The following is a description of a gene set: Human Gene Set: GSE45365_HEALTHY_VS_MCMV_INFECTION_CD11B_DC_IFNAR_KO_DN studied in species Homo sapiens Genes down-regulated in ITGAM+ dendritic cells with IFNAR1 knockout: control versus primary acute viral infection. Murine Cytomegalovirus (MCMV) infection leads to early activation of various immune cells, including B and T lymphocytes, before the actual initiation of antigen-specific adaptive immunity. This activation is partly driven by innate cytokines, including type I interferon (IFN), which are induced early after infection. The objective of this study was to address the role of type I IFN in shaping early/innate B and T cell responses to a primary acute viral infection. In order to decipher the specific impact of IFN-I on cell subsets, we performed a genome-wide expression analysis on WT splenic B and CD8 T lymphocytes isolated from C57BL/6 mixed bone marrow chimera mice. This study complements series GSE39555, which focused on early responses of NK cells and of the two subsets of conventional dendritic cells., and this is the list of marker genes: SEPTIN4, TRIOBP, TK1, NCAPG, STAU2, TMEM26, TEDDM1, LMBRD2, NAV3, ZNRF2P1, BPI, ADAMTS3, MSRB2, SDHC, CDC20, SEPHS2, BCL2L14, KIF15 (NCBI Gene Id 56992), SLC7A9, TOR1AIP2 (NCBI Gene Id 64163), PRKAG3, CLDN1, SNAP91, SKA3 (NCBI Gene Id 221150), LINC01139, TNKS2 (NCBI Gene Id 94771), RBM11, MIR503HG, FRK, G6PD, HPYR1, SSX1, MND1, MKI67, TRIQK, TKT, RASGRF1, UFD1, FIG4, KCNMA1, PCOLCE2, TMEM132D, KIF4A, CYP2B7P, CHMP4C, CDC27, DIRAS3, L3MBTL4, RAB38, CEACAM21, ASPM, GINS1, RNASEK, DHCR7, PPEF2, CXCL6, TMEM107, TRIP13, PDGFC (NCBI Gene Id 56034), KIF14, CENPE, HRH4, HP (NCBI Gene Id 3240), DEPDC1B, PCDHB4, ANLN, EPX, PLK4, RASGEF1B, HJURP, CDCA5, ARF5, ERO1A, PLEKHA2, KIF18B, MTFR2, AIG1, SH3RF1, DDIAS, CNTNAP4, ZNF229, ATP8B3, MELK, GNA14 (NCBI Gene Id 9630), AGTRAP, LUM, COL21A1 (collagen type XXI alpha 1 chain), GAPDH, SPAG5, HAGLR, NKIRAS1, RGS13, DTL, FAM200B, FAM110B (NCBI Gene Id 90362), OR51B5, C1orf226, SEPTIN7P9, HISLA, FFAR3, OTOGL, TRHDE, RNF166, FOXM1, ARHGEF39, FCGR1BP, PLAC8, KRTAP4-1, GRIN3A, GNAO1-DT, GSTM5, INTS6, DIO1, MAGEC2 (MAGE family member C2), PEAK1, MAP2K4, ZNF788P, FAM20A, FIGN, BAD, CIBAR1, SQOR, ADGRE1, CENPF, CDCA8, HNRNPA3P1, LMOD1, SLC16A14, MFAP3, PRELID2, MYO10, MYL6B, CD63, KIF20A, MIPOL1, GSTA3, GPR82, MEIS2, OIP5, NDUFB9, OCRL, AURKA, NKAIN2, TTK, TECTB (tectorin beta), CDKN3, HMMR, SYNJ1, ESYT3, RORB, PCAT18, SHCBP1, HRH1, NEDD4, CALM3 (NCBI Gene Id 808), CFH (NCBI Gene Id 3076), CRNDE, ENSG00000291065, IGHV7-81, HAUS4, VIM, SLC2A10 (solute carrier family 2 member 10), LINC00470, BUB1, NLRC4, NCKAP1L, E2F8, SLC16A4, BTBD19, TBX19, KIF2C, TEX15, HTN1, NPEPPSP1, H2BC12 (H2B clustered histone 12), IFT20, SAMD9L, TMT1B, ATP8B4, KIF27, HBS1L, ZNF619, FGF13-AS1, UMODL1, CEP55, PLD1, PRTN3, PTGR1, TK2, TYRP1, SLC16A3, TM9SF2